The following is a description of a gene set: studied in species Mus musculus Mouse Gene Set: JOHANSSON_BRAIN_CANCER_EARLY_VS_LATE_DN Retroviral tagging previously identified putative cancer-causing genes in a mouse brain tumor model where a recombinant Moloney murine leukemia virus encoding the platelet-derived growth factor B-chain (MMLV/PDGFB) was intracerebrally injected in newborn mice. In the present study, expression analysis using cDNA arrays revealed several similarities of virus-induced mouse gliomas with human brain tumors. Brain tumors with short latency contained on average 8.0 retroviral insertions and resembled human glioblastoma multiforme (GBM) whereas long-latency gliomas were of lower grade, similar to human oligodendroglioma (OD) and had 2.3 insertions per tumor. Several known and novel genes of tumor progression or cell markers were differentially expressed between OD- and GBM-like tumors. Array and quantitative real-time PCR analysis demonstrated elevated expression similar to Pdgfralpha of retrovirally tagged genes Abhd2, Ddr1, Fos, Ng2, Ppfibp1, Rad51b and Sulf2 in both glioma types compared to neonatal and adult normal brain. The retrovirally tagged genes Plekhb1, Prex1, Prkg2, Sox10 and 1200004M23Rik were upregulated in the tumors but had a different expression profile than Pdgfralpha whereas Rap1gap, Gli1, Neurl and Camk2b were downregulated in the tumors. The present study accentuates the proposed role of the retrovirally tagged genes in PDGF-driven gliomagenesis and indicates that insertional mutagenesis can promote glioma progression. from publication Johansson FK, Göransson H, Westermark B (PMID 15750623) Genes down-regulated in early vs late brain tumors induced by retroviral delivery of PDGFB., and this is the list of marker genes: Acot7, Mat2b, Clstn1, Chn1, Lrp1, Igfbp5, Raph1, Pfkm, Gnas, Sparcl1, Aldoc, Ctsd, Caly, Clu, Plekhb2, Ndn, Pla2g7, Pygb, Itm2b, Tef, Gstm1, Gja1, C3 (NCBI Gene Id 12266), Atp1b1, Hdac11, Camk2g, Grina, Csdc2, Ndrg2, Cst3, Cryab, Atp2a2, Ncdn, Mmd2, Ndrg1, Selenop, Nsf, Igfbp4, Ghitm, Qdpr, Dcn, Calm1, Sparc